The following is a description of a gene set: Reactome Pathway: Regulation of TP53 Activity through Acetylation species: Homo sapiens part of: Regulation of TP53 Activity Transcriptional activity of TP53 is positively regulated by acetylation of several of its lysine residues. BRD7 binds TP53 and promotes acetylation of TP53 lysine residue K382 by acetyltransferase EP300 (p300). Acetylation of K382 enhances TP53 binding to target promoters, including CDKN1A (p21), MDM2, SERPINE1, TIGAR, TNFRSF10C and NDRG1. The histone acetyltransferase KAT6A, in the presence of PML, also acetylates TP53 at K382, and, in addition, acetylates K120 of TP53. KAT6A-mediated acetylation increases transcriptional activation of CDKN1A by TP53. Acetylation of K382 can be reversed by the action of the NuRD complex, containing the TP53-binding MTA2 subunit, resulting in inhibition of TP53 transcriptional activity. Acetylation of lysine K120 in the DNA binding domain of TP53 by the MYST family acetyltransferases KAT8 (hMOF) and KAT5 (TIP60) can modulate the decision between cell cycle arrest and apoptosis. Studies with acetylation-defective knock-in mutant mice indicate that lysine acetylation in the p53 DNA binding domain acts in part by uncoupling transactivation and transrepression of gene targets, while retaining ability to modulate energy metabolism and production of reactive oxygen species (ROS) and influencing ferroptosis., and this is the list of marker genes: BRD1, PML, GATAD2A, HDAC2, BRD7, AKT1, PIP4K2C, RBBP7, KAT6A, PIP4K2A, PIN1, MAP2K6, ING2, MEAF6, BRPF3, AKT2, TP53, EP300, PIP4P1, BRPF1, CHD4, HDAC1, PIP4K2B, MBD3, ING5, GATAD2B (GATA zinc finger domain containing 2B), MTA2 (NCBI Gene Id 9219), CHD3, RBBP4, AKT3